Given this list of marker genes Ntrk2, Bdnf (NCBI Gene Id 12064), Phb1, Crebrf, Ncoa2, Akap13, Cry2, Nedd4, Clock, Jak2, Bmal1, Ywhah, Nr3c1, Nr3c2, Ppp5c, Ptges3, Cry1, Per1, Arid1a, Lmo3, here is a description of the gene set: Mouse Gene Set: GOBP_NUCLEAR_RECEPTOR_MEDIATED_CORTICOSTEROID_SIGNALING_PATHWAY A nuclear receptor-mediated signaling pathway initiated by a corticosteroid binding to an intracellular receptor of the nuclear receptor protein family, and ending with regulation of a downstream cellular process, e.g. transcription. species: Mus musculus